The following is a description of a gene set: Binding to an angiotensin receptor. Mouse Gene Set: GOMF_ANGIOTENSIN_RECEPTOR_BINDING species: Mus musculus, and this is the list of marker genes: Bdkrb2 (bradykinin receptor, beta 2), Zbtb16, Ednrb, Arrb2, Agt, Jak2 (NCBI Gene Id 98155), Arrb1, Arap1, Drd1, Tyk2